The following is a description of a gene set: Mouse Gene Set: MIR_7000_3P from publication Chen Y, Wang X (PMID 31504780) species: Mus musculus Genes predicted to be targets of miRBase v22 microRNA mmu_miR_7000_3p in miRDB v6.0 with MirTarget v4 prediction scores > 80 (high confidence targets)., and this is the list of marker genes: Zfp316, Zc3h3, Arih1, Chst7, Tle1, Traf3ip1, Ppp1cb, Pdcd7, Prune1, E2f1, Cbll1, Dcc, Arhgap30 (Rho GTPase activating protein 30), Sema3f, Myo7b, Dag1, Bcl11b, Wdr5, Tnrc6b, Phka1, Fat3, Zfp936, Havcr2